Given this list of marker genes Col4a2, Kifbp, Pthlh, Cmip, H13, Xpnpep1, Prmt7, Dmxl2, Fut8, Gm5544, Gas2l2, Slc20a2, Coro1c, Auts2, Flvcr2, B9d2, Actn4, Ehbp1l1, here is a description of the gene set: from publication Motenko H, Neuhauser SB, O'Keefe M, Richardson JE (PMID 26092688) Mouse Gene Set: MP_EMBRYO_TUMOR Mouse genes annotated to embryo tumor (MP:0014018) retrieved from the Mouse Genome Informatics database via MouseMine species: Mus musculus